Given this list of marker genes RAC1, SLIT3, ARX, SLIT1, SLIT2, here is a description of the gene set: species: Homo sapiens Human Gene Set: GOBP_EMBRYONIC_OLFACTORY_BULB_INTERNEURON_PRECURSOR_MIGRATION The directed movement of individual interneuron precursors during the embryonic development of the olfactory bulb.